The following is a description of a gene set: Overriding aorta An overriding aorta is a congenital heart defect where the aorta is positioned directly over a ventricular septal defect, instead of over the left ventricle. The result is that the aorta receives some blood from the right ventricle, which reduces the amount of oxygen in the blood. It is one of the four conditions of the Tetralogy of Fallot. The aortic root can be displaced toward the front (anteriorly) or directly above the septal defect, but it is always abnormally located to the right of the root of the pulmonary artery. The degree of override is quite variable, with 5-95% of the valve being connected to the right ventricle. Human Gene Set: HP_OVERRIDING_AORTA species: Homo sapiens, and this is the list of marker genes: TMEM270, NDUFB11, GTF2IRD2, GTF2IRD1, RFC2, CHD7, LIMK1, GTF2I, ELN, HCCS, FGFR2, RAI1, COX7B, CLIP2, NEK9, VPS37D, METTL27, FKBP6, EIF4H, BUD23, TBL2, TGDS, DNAJC30, LARS2, BAZ1B, NCF1, STX1A